The following is a description of a gene set: part of: Defective homologous recombination repair (HRR) due to BRCA2 loss of function studied in species Homo sapiens Reactome Pathway: Impaired BRCA2 binding to PALB2 This pathway describes BRCA2 missense mutations that affect the N-terminus of BRCA2 and impair the ability of BRCA2 to bind PALB2, which is a crucial step in homologous recombination repair (HRR) of DNA double-strand breaks (DSBs)., and this is the list of marker genes: TOP3A, KAT5, MRE11, BRIP1, RBBP8, XRCC2, DNA2, BLM, RAD51D, RMI1, NBN, RAD51C, RMI2, RAD50, BARD1, EXO1 (exonuclease 1), WRN, RAD51AP1, PALB2, RAD51B, BRCA2, ATM, RAD51, BRCA1